Given this list of marker genes STAP2, MAST4, MAL, LYPD3, BMP7, SERPINB3, LAD1, ADCY2, TP63, KRT14, TYRP1, KLK10, AKR1C1, AP1G2, ZBED2, PRDX2, SRD5A1, S100A2, KRT16, CDS1, EGFR, LORICRIN, CA12, SCUBE2, CDHR1, COL7A1, SPINT2, ITGB4, C1orf116, CWH43, SCNN1A (NCBI Gene Id 6337), TP53AIP1, CALML5, PLP2, DSP, COL4A6, CA2, BTG1, JAG1, S100A9, BICD2, GNA15, ABHD2, SOWAHC, CDH3, ALDH3B2, SLC2A1, ASPA, COL17A1, TUFT1, CTNND1, PALMD, ECHDC2, RAB25, RORA, TUBA4A, CLCA2, KCND3, LTB4R, ESRP2, PDZK1IP1, PAK6, IMPA2, ARHGAP32, S100A7, FGFBP1, COBL, CLIC3, MCOLN3, DPP6 (NCBI Gene Id 653748), ARHGEF4, ZNF185, ITM2A, CRYBG1, CCL27, ASS1, PTCH1, KLRF1 (NCBI Gene Id 51348), PTPRZ1, ANK3, MYO6, DNASE1L3, PRSS3, RAPGEFL1, MPZL2, KRT6A, NRCAM (NCBI Gene Id 4897), SERPINB13, SPINK5, GPR87, EHF, AOPEP, PLPPR4, HCAR3, TM4SF1, JUP, KRT15, DSG3, CD24, S100A14, FCGBP (NCBI Gene Id 8857), GSTT1, GRHL2, QPCT, FAT2, CXCL14, EPPK1, LSR, TRIM29, S100A8, SOX15, KIT, DUOX1, FZD10, ARAP2, CXADR, DSC2, AKR1B10, PKP3, S100P, SCEL, CKMT1B, BBOX1, LAMA3, MATN2, CDH1, MMP28, KRT5, KLF5, CLTB, DUSP7, EFS, LAMC2, ABLIM1, DIO2 (iodothyronine deiodinase 2), GPX2, PI3, DST (NCBI Gene Id 80105), IVL, AQP3, TMEM45A, NFIB (NCBI Gene Id 4781), THBD, ETS2, BCL11B, KRT33A, SSH3, EPHX3, CHN2, FGFR2, LAMB3, NET1 (neuroepithelial cell transforming 1), ABCA12, ALDH2, IRX4, BCL11A, HLF, LTF, ABCC3, SFN, CD207, PLXNC1, PPL, PRSS8, KLK8, POU2F3 (POU class 2 homeobox 3), DSC1 (desmocollin 1), SLC1A4, WNT5A, NLRX1, PYCARD, DSC3, TFAP2B, FLG, ENPP2, TXNIP, LY6D, LGALS7, LGR5, GABRE, CSTA (cystatin A), KRT1, NAP1L2, PER2, KLF4, FCER1A, FHOD3, GJB3, PERP, EPHB6, KRT10, FXYD3, DSG1, CD24P2, MAPK13, PKP1, MAF, ACKR4, MID2, TFAP2C, IRF6, DEFB1, DGKA, KRT19, AREG, CDA (NCBI Gene Id 978), GATA3, TACSTD2, NMU, CHP2, NEBL, EVPL (NCBI Gene Id 2125), FERMT1, TPD52L1, INAVA, SPRR1A, FST, ZNF750, HAL, SLPI, GJA1, ST14, EXPH5, MST1R, SDC1, SERPINB4, KRT23, KRT31, SCGB2A2, CTNNBIP1, KLK11, HOPX, CTXND1, TPSAB1, ELMO3, AHNAK, VSNL1, IL1R2 (interleukin 1 receptor type 2), MT1M (NCBI Gene Id 4499), CST6, KRT6B, ITPR3, F2RL1, CRYBG2, CALML3 (NCBI Gene Id 810), PRELP (NCBI Gene Id 5549), FGFR3, ANXA8, PTGS1, KRT17, CPA3, PCSK2, NTRK2, CTSG (NCBI Gene Id 1511), CFH, SPRR1B, MAP7, CYP26B1, KLK7, here is a description of the gene set: species: Homo sapiens Human Gene Set: JAEGER_METASTASIS_DN Genes down-regulated in metastases from malignant melanoma compared to the primary tumors. from publication Jaeger J, Koczan D, Thiesen HJ, Ibrahim SM, Gross G, Spang R, Kunz M (PMID 17289871) PURPOSE: To better understand the molecular mechanisms of malignant melanoma progression and metastasis, gene expression profiling was done of primary melanomas and melanoma metastases. EXPERIMENTAL DESIGN: Tumor cell-specific gene expression in 19 primary melanomas and 22 melanoma metastases was analyzed using oligonucleotide microarrays after laser-capture microdissection of melanoma cells. Statistical analysis was done by random permutation analysis and support vector machines. Microarray data were further validated by immunohistochemistry and immunoblotting. RESULTS: Overall, genes were identified that showed significant differential expression between primary melanomas and melanoma metastases (false discovery rate<or=0.05). Significantly overrepresented gene ontology categories in the list of genes were cell cycle regulation, mitosis, cell communication, and cell adhesion. Overall, genes showed up-regulation in metastases. These included Cdc6, Cdk1, septin 6, mitosin, kinesin family member 2C, osteopontin, and fibronectin. Down-regulated genes included E-cadherin, fibroblast growth factor binding protein, and desmocollin 1 and desmocollin 3, stratifin/14-3-3sigma, and the chemokine CCL27. Using support vector machine analysis of gene expression data, a performance of >85% correct classifications for primary melanomas and metastases was reached. Further analysis showed that subtypes of primary melanomas displayed characteristic gene expression patterns, as do thin tumors (<or=1.0 mm Breslow thickness) compared with intermediate and thick tumors (>2.0 mm Breslow thickness). CONCLUSIONS: Taken together, this large-scale gene expression study of malignant melanoma identified molecular signatures related to metastasis, melanoma subtypes, and tumor thickness. These findings not only provide deeper insights into the pathogenesis of melanoma progression but may also guide future research on innovative treatments.